Given this list of marker genes TMEM270, SLC19A3, RTN2, RAD51, GTF2I, PRPH, CLIP2, NIPA1, SLC33A1, GALC, ATXN8OS, PLP1 (NCBI Gene Id 5354), SPG11, DPYS, LIMK1, TARDBP, ELN, FUS, DCC (DCC netrin 1 receptor), VCP, PDHB, FKBP6, SQSTM1, VAPB, KPNA3, PRKRA, TBK1, ENSG00000288330, ABCD1, SOD1, TBL2, DNAJC30, AIFM1, NEFH, KCNC3, SPAST, SPG7, GTF2IRD2, GAN, VPS37D, BAZ1B, SLC2A1, DNAL4, PLA2G6, WASHC5, RFC2, TREX1, BUD23, NCF1, STX1A, L1CAM, DCTN1, CTC1, CHCHD10, FKTN, ALS2, UBAP1, GTF2IRD1, L2HGDH, SLC6A3, CPT1C, MT-ATP6, ATL1, METTL27, ATXN10, PRNP, ATP1A2, MAPT, EIF4H, NTN1, here is a description of the gene set: Any structural abnormality of the pyramidal tract, whose chief element, the corticospinal tract, is the only direct connection between the brain and the spinal cord. In addition to the corticospinal tract, the pyramidal system includes the corticobulbar, corticomesencephalic, and corticopontine tracts. Human Gene Set: HP_ABNORMAL_PYRAMIDAL_TRACT_MORPHOLOGY Abnormal pyramidal tract morphology studied in species Homo sapiens